Given this list of marker genes DOCK1, KCNK5, IL2RA, HOXB2, ADGRG1, SCHIP1, PLA2G4A, PLS1, GOLGA8A, PTP4A3, GRB10, HBB, TRIM16, LAPTM4B, JAG1, MAP4K4, PIM1, GUCY1A1, ARHGAP22, CLU, SRSF8, HOXA5, LPIN1, EZR (ezrin), CCL1, TRPC2, PDE3B, HBA1, GLI2, here is a description of the gene set: studied in species Homo sapiens BACKGROUND: In patients with acute myeloid leukemia (AML) a combination of methods must be used to classify the disease, make therapeutic decisions, and determine the prognosis. However, this combined approach provides correct therapeutic and prognostic information in only 50 percent of cases. METHODS: We determined the gene-expression profiles in samples of peripheral blood or bone marrow from 285 patients with AML using Affymetrix U133A GeneChips containing approximately 13,000 unique genes or expression-signature tags. Data analyses were carried out with Omniviz, significance analysis of microarrays, and prediction analysis of microarrays software. Statistical analyses were performed to determine the prognostic significance of cases of AML with specific molecular signatures. RESULTS: Unsupervised cluster analyses identified 16 groups of patients with AML on the basis of molecular signatures. We identified the genes that defined these clusters and determined the minimal numbers of genes needed to identify prognostically important clusters with a high degree of accuracy. The clustering was driven by the presence of chromosomal lesions (e.g., t(8;21), t(15;17), and inv(16)), particular genetic mutations (CEBPA), and abnormal oncogene expression (EVI1). We identified several novel clusters, some consisting of specimens with normal karyotypes. A unique cluster with a distinctive gene-expression signature included cases of AML with a poor treatment outcome. CONCLUSIONS: Gene-expression profiling allows a comprehensive classification of AML that includes previously identified genetically defined subgroups and a novel cluster with an adverse prognosis. Human Gene Set: VALK_AML_CLUSTER_2 Top genes from cluster 2 of acute myeloid leukemia (AML) expression profile; 71% of the samples are FAB M4 or M5 subtypes, and 82% bear internal tundem duplications in FLT3. from publication Valk PJ, Verhaak RG, Beijen MA, Erpelinck CA, Barjesteh van Waalwijk van Doorn-Khosrovani S, Boer JM, Beverloo HB, Moorhouse MJ, van der Spek PJ, Löwenberg B, Delwel R (PMID 15084694)